Given this list of marker genes RUFY1, GPRASP3, LINC01732, TSC1, ALG1, PPP4R1L, TSR3, FEN1, XKR9, LINC01703, ZZZ3, MCOLN1, TRMT1, FAM118B, RPUSD4, GTF2A1-AS1, ALDH6A1, TMEM258, LRRC37A3, FAM21EP, SNX8, VPS35L, AKR7A2, NOL8, GBA1LP, RNF220, KLHL12, CEP162, MARCHF8, HEXA-AS1, POLDIP2 (DNA polymerase delta interacting protein 2), COMMD9, CENPP, RPS29P16, NUDCD3, FOXM1, GRN, ATP6AP1, USP31 (ubiquitin specific peptidase 31), DVL2, HNRNPH2, MIR548AW, UBE2Q1, WASHC2A, SREK1, SBNO1 (strawberry notch homolog 1), MED28, CLN3, ARL8B, STRIP1 (NCBI Gene Id 85369), VPS11, VPS33A, SUMF1, HEXA (hexosaminidase subunit alpha), MED28-DT, NAGPA, ATF7IP2, ZNF292, FDX2, VSIG10L-AS1, NUDC, SUPV3L1 (Suv3 like RNA helicase), DNAJC8, GLA, DPP7, CARD8-AS1, ATG14, RMND1 (required for meiotic nuclear division 1 homolog), BAX, ITGA7, ZNF507, LINC02252, TOM1, RCBTB1, SIRT1, TMEM199, ATP6V1G1, MIR4766, SLC38A7, VAC14, NAGLU, PDE12, MFSD5, SPNS1, UROD, NRBF2, EOGT, MTHFR, MFF, ATP6V1H, LIN52, SLC25A12, HECTD3, RAD9A, RHNO1, FAM21FP, VPS26A, VSIG10L, SLC36A1, RIMOC1, SPINK9, ARMT1, RETREG2, SHPK, MILIP, TULP3, ATP6AP1-DT, CSTB, UTP20, GPATCH3, COMMD4, MIR3928, AMDHD2, USF2, GNPTG, DOHH (NCBI Gene Id 83475), OPLAH, COLEC11, AP5Z1, SLC35B2, ASPSCR1, TMC6, QTRT1, WWP2, ISLR2, GFI1B, RNF185, PAPPA, PES1, KAT5, FAHD1, VMA21, COA7 (cytochrome c oxidase assembly factor 7), GAA (alpha glucosidase), ENSG00000272008, MAFG, RENBP, STX4, GET3, EPS15L1, GALC, CNPPD1, SPPL3 (signal peptide peptidase like 3), ZFYVE26, GATB, ARFGEF2, SYT12, AFF4, GTF2A1, RAB22A, SLC66A1, RCAN1, HAGH, GUSBP12, ZC3H18, CLCN6, BROX, PPT1, SKAP2, GABARAP, GBA1, TPP1, RIN3, VPS11-DT, WASHC5, TNK2-AS1, TCN2, WASHC2C, MFF-DT, GIT2, SBNO1-AS1, CTSD, UBE4B, AIDA, RAB21, FNDC3A, CTSA, ATP6V1C1, GALNS, PEPD, AGTRAP, SEC24C, ATP6V0C, AFF4-DT, LYG2, IGF2R, ARHGAP12, VPS41, LAMP1, LINC01164, NEURL2, CPNE2, CTNS, METAP1D, CLCN7, BLOC1S1, NSMCE2, LMTK2, TRMO, LACTB2, ENSG00000260288, FADS2, SMCR8, MFSD1, TOP3A, TRAPPC2L, WDR81, HPS1, here is a description of the gene set: Human Gene Set: ZNF354B_TARGET_GENES species: Homo sapiens from publication Yevshin I, Sharipov R, Kolmykov S, Kondrakhin Y, Kolpakov F (PMID 30445619) Genes containing one or more binding sites for (ZNF354B) in their promoter regions (TSS -1000,+100 bp) as identified by GTRD version 20.06 ChIP-seq harmonization.